Given this list of marker genes IGFBP4, IGF1, SGPP2, RASGRF1 (NCBI Gene Id 9983), PTPRN, PDX1, PHOX2B, NR4A3, ERRFI1, NR1D1 (NCBI Gene Id 9572), RAF1 (Raf-1 proto-oncogene, serine/threonine kinase), BGLAP, BAD, WDR13, NR4A1, IGFBP5, FMC1, DACH1, NUPR1, SERPINB1, BTBD10, IRS2, CDK4, IGFBP3, ANGPTL8, MAP2K1, CCN3, SIDT2, NKX6-1, here is a description of the gene set: The multiplication or reproduction of pancreatic B cells, resulting in the expansion of an pancreatic B cell population. Pancreatic B cell are cells of the pancreas that secrete insulin. species: Homo sapiens Human Gene Set: GOBP_TYPE_B_PANCREATIC_CELL_PROLIFERATION